Given this list of marker genes SMARCA1, JAG1, NR3C1, SNRPB2, SLCO2A1, STK38, CSNK2A1, DAPK1, NNT, ANXA7, PIK3CD, here is a description of the gene set: Human Gene Set: ROZANOV_MMP14_CORRELATED species: Homo sapiens Genes whose expression most uniformly correlated with that of MMP14 both in HT1080 cells (fibrosarcoma) and in 190 human tumors. from publication Rozanov DV, Savinov AY, Williams R, Liu K, Golubkov VS, Krajewski S, Strongin AY (PMID 18519667) Invasion-promoting MT1-MMP is directly linked to tumorigenesis and metastasis. Our studies led us to identify those genes, the expression of which is universally linked to MT1-MMP in multiple tumor types. Genome-wide expression profiling of MT1-MMP-overexpressing versus MT1-MMP-silenced cancer cells and a further data mining analysis of the preexisting expression database of 190 human tumors of 14 cancer types led us to identify genes, the expression of which correlated firmly and universally with that of MT1-MMP (P < 0.00001). These genes included regulators of energy metabolism (NNT), trafficking and membrane fusion (SLCO2A1 and ANXA7), signaling and transcription (NR3C1, JAG1, PI3K delta, and CK2 alpha), chromatin rearrangement (SMARCA1), cell division (STK38/NDR1), apoptosis (DAPK1), and mRNA splicing (SNRPB2). Our subsequent extensive analysis of cultured cells, tumor xenografts, and cancer patient biopsies supported our data mining. Our results suggest that transcriptional reprogramming of the specific downstream genes, which themselves are associated with tumorigenesis, represents a distinctive molecular signature of the proteolytically active MT1-MMP. We suggest that the transactivation activity of MT1-MMP contributes to the promigratory cell phenotype, which is induced by this tumorigenic proteinase. The activated downstream gene network then begins functioning in unison with MT1-MMP to rework the signaling, transport, cell division, energy metabolism, and other critical cell functions and to commit the cell to migration, invasion, and, consequently, tumorigenesis.